Given this list of marker genes TGFBI, NCAPG2, SIX6, ZNF469, MPV17, PRDM12, OCRL, PRDM5, ERCC4, CREBBP, DST, UROS, NTRK1, COL7A1, EP300, ZFHX2, GJB2 (NCBI Gene Id 2706), NGLY1, COL17A1, POLA1, here is a description of the gene set: Human Gene Set: HP_CORNEAL_SCARRING studied in species Homo sapiens Corneal scarring